The following is a description of a gene set: Human Gene Set: GOBP_POSITIVE_REGULATION_OF_FAT_CELL_DIFFERENTIATION studied in species Homo sapiens Any process that activates or increases the frequency, rate or extent of adipocyte differentiation., and this is the list of marker genes: TMEM64, SIX1, HTR2A, CMKLR1, HTR2C, LMO3, WDFY2, GDF3, LRP5, HNRNPU, FFAR4, AXIN2, RREB1, MIR29B1, AAMDC, CEBPA, ZBTB7C, STK4, MAPK14, ZBTB16, PTGS2, CREB1, MIR21, FRZB, NOCT, CARM1, ADIG, STK3, CEBPB, PPARD, MIR17, ZBTB7B, PIM1, DKKL1, RARRES2, ZFP36, TRPM4, NAPEPLD, SYAP1, CREBL2, CDS1, CCDC3, SIRT6, MEDAG, LPL, SOX13, TPH1, SFRP2, METRNL, INS, AKT1, XBP1, ZFP36L1, FNDC5, BMP2, SULT1E1, WIF1, ASXL2, ZC3H12A, ID2, BMP7, TFE3, SFRP1, MIR106A, VSTM2A, KLF5, ZNF385A, WNT5B, ADIRF, SNAI2, SAV1, PPARG